The following is a description of a gene set: Genes in the red cluster of protein kinases distinguishing between luminal A and basal breast cancer subtypes. studied in species Homo sapiens from publication Finetti P, Cervera N, Charafe-Jauffret E, Chabannon C, Charpin C, Chaffanet M, Jacquemier J, Viens P, Birnbaum D, Bertucci F (PMID 18245477) Breast cancer is a heterogeneous disease made of various molecular subtypes with different prognosis. However, evolution remains difficult to predict within some subtypes, such as luminal A, and treatment is not as adapted as it should be. Refinement of prognostic classification and identification of new therapeutic targets are needed. Using oligonucleotide microarrays, we profiled 227 breast cancers. We focused our analysis on two major breast cancer subtypes with opposite prognosis, luminal A (n = 80) and basal (n = 58), and on genes encoding protein kinases. Whole-kinome expression separated luminal A and basal tumors. The expression (measured by a kinase score) of genes encoding serine/threonine kinases involved in mitosis distinguished two subgroups of luminal A tumors: Aa, of good prognosis and Ab, of poor prognosis. This classification and its prognostic effect were validated in 276 luminal A cases from three independent series profiled across different microarray platforms. The classification outperformed the current prognostic factors in univariate and multivariate analyses in both training and validation sets. The luminal Ab subgroup, characterized by high mitotic activity compared with luminal Aa tumors, displayed clinical characteristics and a kinase score intermediate between the luminal Aa subgroup and the luminal B subtype, suggesting a continuum in luminal tumors. Some of the mitotic kinases of the signature represent therapeutic targets under investigation. The identification of luminal A cases of poor prognosis should help select appropriate treatment, whereas the identification of a relevant kinase set provides potential targets. Human Gene Set: FINETTI_BREAST_CANCER_KINOME_RED, and this is the list of marker genes: CDC7, SRPK1, MELK, NEK2, AURKB, CDK1, PLK4, PBK, BUB1, PLK1 (NCBI Gene Id 5347), TTK, BUB1B, MASTL, AURKA, CHEK1, VRK1